Given this list of marker genes LATS1, WDFY1, TNFAIP3, USP17L2, TKFC, ZCCHC3, LAMP2, MARK4 (microtubule affinity regulating kinase 4), PRKDC, SMPDL3A, PELI1, TASL, PTPN22, NR1H3, BPIFB1, ATAT1, PIK3R1, MARCHF5, AURKB, S100A9, ZDHHC18, NFKBIL1, S100A8, PYDC2, OASL, RNF39, RAB7B, NLRC3, ITCH, CD300LF (CD300 molecule like family member f), PDPK1, PYDC5, NR1D1, MAPK8, MIR210, AARS2, LBP, RTN4, ESR1, LATS2, DHX58, CAV1, CPTP, DHX33, MYD88, MIR19A, DDX3X, GBP5, NOP53, CYBA, HSPA1A, TLR1, GBP2, MIR17, C1QBP, NEK7, TRIM32, RSAD2, LILRA4, DDX60, TRIM15, LYPLAL1, SMPDL3B, IRGM, USP50, HMGB1, MFHAS1, MIR149, NAGK, MIR200C, ARRB2, CD36, ZDHHC3, SLC15A2, UFD1, PARP1, MAP3K7 (NCBI Gene Id 6885), ZDHHC1, GPATCH3, ERBIN, IFI35, SIRT2, TLR6, TLR9, TIRAP, IRF7, FBXL2, KCNK13, BANF1, LRCH4, PPT1, MAVS, BIRC2, HSPA8, NLRX1, APPL1, NLRP2B, CSNK1A1 (casein kinase 1 alpha 1), MIR4691, APP, ACOD1, NPLOC4, RNF125, CCDC134, BIRC3, UBQLN1, TRIM65, BTK, PTPRS, TAX1BP1, NINJ1, TRIM11, DAB2IP, PJA2, MIR200B, KCNK6 (NCBI Gene Id 9424), SPSB3, GRAMD4, USP15, BRCC3, F2RL1, GPS2, MEFV, RIOK3, XIAP, GFI1, SLC15A3, TYRO3, FCRL3, PCBP2, TRIM3, MIR146A, MIR708, FLOT1 (NCBI Gene Id 10211), TRIM31, HCFC2, LGR4, HDAC6, LILRA2, CARD8, FLOT2, IRAK3, ZNRF4, RNF115, MIR20A, P2RX7, ZDHHC5, PPP6C, HSPA1B, PUM1, AKT1, ABHD8, SARM1 (sterile alpha and TIR motif containing 1), TREX1, GDI1, SLC19A1, SEC14L1, CD300A, PLCG2, LTF, LRRC14, TAB1, GPR108, TREML4, HSP90B1, TREM2, ANKRD17, TLR4, IRF1, EIF2AK2, TICAM2, SLC46A2, IFI16, NLRP6, ZNRF1, PYDC1, APPL2, ZDHHC12, LYN, IRF4 (NCBI Gene Id 4592), STMP1, PUM2, ZDHHC9, PRKD1, SQSTM1, CGAS, PPP2CA, ZC3HAV1, YWHAE, MIR140, SRC, TSPAN6, OTUD4, TARBP2, OGT, CACTIN, IKBKB, CD14, ABHD17A, SLC15A4, here is a description of the gene set: Any process that modulates the rate, frequency or extent of a pattern recognition receptor signaling pathway. species: Homo sapiens Human Gene Set: GOBP_REGULATION_OF_PATTERN_RECOGNITION_RECEPTOR_SIGNALING_PATHWAY